The following is a description of a gene set: studied in species Homo sapiens Genes down-regulated in lymph node B lymphocytes: influenza infected versus interferon beta stimulation. from publication Chang WL, Coro ES, Rau FC, Xiao Y, Erle DJ, Baumgarth N (PMID 17237394) Influenza virus infection-induced gene expression changes of regional B cells are mediated at least in part through type I Interferon: Our objective is to determine whether the influenza virus-infection induced gene expression changes in regional lymph node B cells are facilitated at least in part through type I interferon. Our specific aim is to compare the gene expression profile of highly FACS-purified B cells in the regional lymph nodes of wildtype and IFNR-/- mice prior to and 48h following infection with influenza virus infection and to contrast this expression profile with that of FACS-purified wildtype B cells activated in vitro with IFN-beta +/- anti-CD86 for 12h. Human Gene Set: GSE3203_INFLUENZA_INF_VS_IFNB_TREATED_LN_BCELL_DN, and this is the list of marker genes: MOB3B, SOCS2, LSM11, TMEM255A, HSD17B2, CCS, SNX33, SENP6, NLRC3, GOLM2, NAP1L3, IGF1R (insulin like growth factor 1 receptor), CABCOCO1, P2RX7, PKD1L2, SMS, POP4, TRUB1, NBDY, CSTPP1 (NCBI Gene Id 79096), MCTP2, RRP1B, OSBPL5, DUSP5, ADSS1, MDM4, BCL6, PHGDH, TBC1D32, NEFH (neurofilament heavy chain), PIK3IP1 (NCBI Gene Id 113791), PLEKHA1, QTRT1, VCL, LPIN2, MFHAS1, B9D1, ACKR3, PUS7L, HS2ST1, DPYD, PUS1, CHKA, CCND2, COQ6, GOLM1 (NCBI Gene Id 51280), MYMK (myomaker, myoblast fusion factor), LRRC36, PLGRKT, LAP3, RASGRP2, HOMER1, SEPHS1, DHX33, ILF2, LACC1, DCAF1, SPATA7, ST3GAL4, USP32, PARD6G, SVIL, DCTD, TMEM154, NUDT14, SLCO5A1, SHISA4, DNPH1, LRATD2, HEXD, SLC7A3, C17orf58, WDR13, MRPL37, DDI2, TUBA8 (tubulin alpha 8), PLEC, FKBP11, ANKLE2, ABCD3, PRPF39, SPACA9, FBXW10, ARGLU1, ZNF12, SSR4, ZNF706, COLGALT1, PCGF6, SSPN, INPPL1, ELOVL5, GOT2, PLA2G4A, ATAD3A, MGA, PPAN, STARD6, POMP, SPAG17, CAPG, HADH, CBR3, NOP58, PLA2R1, SSX2IP, PTPRE, PRMT3, MARVELD1, TERT, ITGB1, NOP16, FRRS1, PRKCQ, ANXA1, FMR1, PRICKLE3, ABCA4, RPL32, RAB3GAP2, LMLN, SMIM3, RPL24, PPIG, NDUFAF6, RELT, SFMBT2, KCNK6, CLIC3, PECR, TMEM176B, IRS1, S100A6, ZNF280C, EBI3, WWOX, STAG1, GLG1, XXYLT1, DSE, SLC36A4, MATK, CD99, BEX1, ABCG2, ATXN1, KPNA3, NID1, TDRD9, ARID5A, LCLAT1, ACSL1, SNX10, KMT5A, PTGER4, UBXN2A, CLDN10, SLC49A4, ENTPD1, AUH, ARL5A, ERCC6L2, POGLUT3, EMB, ST14, DCTPP1, CARMIL1, STEAP3, ABCC4, RPS9, SHISA9, CYP7B1, FAM98B, TMEM201, ARMC3, PFKFB3, DAG1, ANKRD33B, TNMD (tenomodulin), SIDT1, RBMS1, KCNC2, TRIM44, TGFB2, GSR, ROGDI, ZCCHC3, SYNE2, MSANTD1, ANKIB1, HOATZ, CSF2RB, TACC3, DPP4, ANXA2, TBC1D24, PTCH1, BOLA2, NAB1, MOGS